Given this list of marker genes SLC25A44, STXBP1, ARL6IP1, SLC38A9, VPS54, SLC38A3, SLC7A7, SLC25A38, LRRC8A, ARL6IP5, SLC7A11, LRRC8B, SLC7A10, SLC22A15, AVPR1A, GFAP, SLC1A1, SLC1A3, NTRK2, LEP, SLC6A18, ATP1A2, GJA1, SLC22A2, TTYH3, LRRC8C, SLC36A2 (NCBI Gene Id 153201), DTNBP1, SFXN4, SLC6A2, SLC25A12, KCNK1, SLC7A9, SLC6A16, TTYH1, SLC6A13, SLC7A5P2, SLC3A1, SLC6A11, SLC25A13 (solute carrier family 25 member 13), SLC43A2, SLC36A4, SLC7A13, KCNK2, SH3BP4, SLC6A20, EPM2A (NCBI Gene Id 7957), LRRC8E, SLC6A9, KCNJ10, SLC1A6, NFE2L1, SLC16A10, SLC7A1, SLC38A2, SLC22A4, GRM7, SFXN3, SLC7A4, TNF, SLC1A7, SLC16A2, GRM1, NTSR1, ADORA2A, SLC38A6, SLC6A12, SLC6A1, SLC6A19, SLC38A7, CLTRN, NF1, SFXN1, SLC7A14, SLC66A1LP, SLC6A14, SLC43A1, RAB3GAP1, SLC7A5, AVP, SEPTIN2, PSEN1, SERINC5, MFSD12, SLC47A1, SLC38A8, SLC6A3, KCNJ8, SLC25A2, RGS2, SLC25A26, PRKG1, PIANP, SLC38A10, SLC17A8, SLC7A3, TSPO2, SLC6A6, LRP5, SLC7A8, PDPN, ABAT, TRPC4, RGS4, PRAF2, SLC25A15, SLC6A15, SLC17A7, SLC7A6, TMEM44, GRM2 (glutamate metabotropic receptor 2), TTYH2, SLC66A1, SLC12A2 (NCBI Gene Id 6558), SLC6A8, SLC36A3, SLC36A1, SFXN5, GIPC1, CLN3, ABCC8, PER2, SLC38A5, CTNS, SLC7A2, CACNB4, SLC32A1, SNCA, SERINC3, SLC1A5, SLC1A4, APBA1, LLGL2, SLC3A2, SLC11A1, CLN8, SLC1A2, XK, SYT4, SLC6A4, BEST1, LRRC8D, ACE2, SLC25A18, SLC17A5, P2RX7, KMO, GNAT2, ADORA1, SLC6A5, SLC17A6, SLC25A22, NHERF1, UCP2, TRH, SLC25A29, NPY5R, SLC6A17, GABBR1, SFXN2, SLC6A7, SLC7A5P1, SLC38A1, SLC15A4, SLC38A11, SLC38A4, ITGB1, here is a description of the gene set: studied in species Homo sapiens The directed movement of amino acids, organic acids containing one or more amino substituents, into, out of or within a cell, or between cells, by means of some agent such as a transporter or pore. Human Gene Set: GOBP_AMINO_ACID_TRANSPORT